The following is a description of a gene set: studied in species Mus musculus Reactions specific to the complex N-glycan synthesis pathway Mouse Gene Set: REACTOME_REACTIONS_SPECIFIC_TO_THE_COMPLEX_N_GLYCAN_SYNTHESIS_PATHWAY, and this is the list of marker genes: Cga, Mgat2 (mannoside acetylglucosaminyltransferase 2), Chst10, Lhb, Fuca1, Man2a2, Man2a1, Chst8, Fut8